Given this list of marker genes Mcoln2, Ryr2, Cnga2, Trpv1, Hcn4, Hcn2, Ryr1, Mcoln1, Hcn1, Tpcn1, Trpa1, Cnga3 (NCBI Gene Id 12790), Cngb3, Ryr3, Aqp1, Cnga4, Hcn3, Bnip1 (NCBI Gene Id 76517), Pkd2, Best2, Cngb1, Cftr, Itpr2, Rasa3, Cnga1 (NCBI Gene Id 12788), Tpcn2, Pex5l, Trpm2, Itpr1, Itpr3, Mcoln3, here is a description of the gene set: Mouse Gene Set: GOMF_INTRACELLULARLY_LIGAND_GATED_MONOATOMIC_ION_CHANNEL_ACTIVITY studied in species Mus musculus Enables the transmembrane transfer of an ion by a channel that opens when a specific intracellular ligand has been bound by the channel complex or one of its constituent parts.